Given this list of marker genes RAMP2, NOTCH1, NFATC4, EDNRA (endothelin receptor type A), EFEMP2, ENG, ADM (NCBI Gene Id 133), HEY2, COMP (NCBI Gene Id 5659), SGCB, HES1, VEGFA, here is a description of the gene set: Human Gene Set: GOBP_VASCULAR_ASSOCIATED_SMOOTH_MUSCLE_CELL_DEVELOPMENT species: Homo sapiens The process aimed at the progression of a vascular smooth muscle cell over time, from initial commitment of the cell to a specific fate, to the fully functional differentiated cell. A vascular smooth muscle cell is a non-striated, elongated, spindle-shaped cell found lining the blood vessels.